Given this list of marker genes Il1a, Tifa, Pycard, Prkd1, Tnf, Il1r1, Gapdhrt, Map3k7, Trim30d, Gapdh-ps15, Xiap (X-linked inhibitor of apoptosis), Htr2b, Trim62, Cd36, Tnfrsf1a, Ccl21e, Cd4, Tnfsf11, Ccl19-ps1, Irf3, Casp8, Tnfsf15, Edn1, Tlr6, Prl, F2r, Ddx21, Trim25, Insr, Clec7a, Clec4d, Tnip2, Ccl19-ps6, Clec4n, Nup62, Abl2, Trim30a, Mtdh, Flna, Irak1, Faim, Tank, Lurap1l, Malt1, Tlr9, Tab3, S100a13, Tnfsf14, Ticam1, Huwe1, Ankrd17 (ankyrin repeat domain 17), Ednra, Ube2n, Agt, Lrrc19, Rbck1, Terf2ip, Ikbkg, Trim38, Lims1, Cav1, Cul1, Ednrb, Ccl21b, Trim13, Adipoq, Myd88, Cth, Ctnnb1, Ddx1, Lurap1, Tfrc, Ajuba, Tgm2, Ccl19, Tifab, Rbx1, Sharpin (SHANK-associated RH domain interacting protein), S100b, Prkce, Lpar1, Rnf31, Ccdc22, Ilk (integrin linked kinase), Irak1bp1, Traf3ip2, Chuk, Ripk2, Trim12a, Traf5, Map3k3, Tlr3, Dab2ip, F2rl1, S100a4, Rela, Ccl21a, Zc3hav1, S100a7l2, Ccl19-ps4, Brd4, Akap13, Ccl21f, Card11, Tlr7, Cx3cr1, Atp2c1, Trim8, Tnfsf10, Cx3cl1, Trim30c, Pink1, Nfat5, Cd40, Ltf, Peli1, Inava, Ccl19-ps5, Ror1 (NCBI Gene Id 72176), Gprc5b, Eda2r, Trim30b, Il1b, Prkcb, Ltbr, Abl1, Irak2, Lta, Pim2, Trim12c, Fbxw11, Trim52, Tlr4, Irak4, Mul1, Mas1, Ubd, Parp1, Traf6, Gapdh, Card10, Nod1, Alpk1, Trim32, Fasl (NCBI Gene Id 14103), Tradd, Ltb, Irak3, Trim5, Tirap, Dhx15, Ikbkb, Ticam2, Ccl19-ps3, Ikbke, Fadd, Cd74, Traf2, Jmjd8, Flot1, Ripk1, Birc2, Gapdhrt2, Dhx36, Tbk1, Unc5cl, Ccl21d, Casp1, Tgfb1, Tlr8, Card14, Edar, Litaf, Cd40lg, Tnfrsf19, Mid2, Prkn, Bcl10, Tmem106a, Nod2, Eda, Ube2i (NCBI Gene Id 76085), Tab2, Card9, Rbx1-ps, Rhoa, Lamtor5, Flot2, Nampt, here is a description of the gene set: species: Mus musculus Any process that activates or increases the frequency, rate or extent of a canonical NF-kappaB signaling cascade. Mouse Gene Set: GOBP_POSITIVE_REGULATION_OF_CANONICAL_NF_KAPPAB_SIGNAL_TRANSDUCTION